Given this list of marker genes HES7, COL3A1, THSD1, ANGPTL6, ENG, TGFBR3, here is a description of the gene set: Abnormal circle of Willis morphology An anomaly of the circle of Willis, also known as the cerebral arterial circle. Human Gene Set: HP_ABNORMAL_CIRCLE_OF_WILLIS_MORPHOLOGY studied in species Homo sapiens